The following is a description of a gene set: The aim of this study is to survey global gene expression of total thymocytes from wild-type mice and Atg16l1 mutant (hypomorph) mice. from publication Cadwell K, Liu JY, Brown SL, Miyoshi H, Loh J, Lennerz JK, Kishi C, Kc W, Carrero JA, Hunt S, Stone CD, Brunt EM, Xavier RJ, Sleckman BP, Li E, Mizushima N, Stappenbeck TS, Virgin HW 4th (PMID 18849966) Genes up-regulated in tymocytes: mutant (hypomorph) ATG16L1 versus wildtype. Human Gene Set: GSE12707_AT16L1_HYPOMORPH_VS_WT_THYMUS_UP species: Homo sapiens, and this is the list of marker genes: PES1 (NCBI Gene Id 23481), BCCIP, ASB2, NASP, CFI, NT5C1B, ANK2 (ankyrin 2), TMPRSS11D, LELP1, GUCY1B2, COPS3 (COP9 signalosome subunit 3), GJA4, MRPL16, RNASEH2B, PEX11A, LIAS, CD177 (NCBI Gene Id 57126), CFAP144P1, HELLS, SLC16A11, NGRN (NCBI Gene Id 51335), BTBD10, MRTO4, NUP155, LY6S, CTH, ACSF3, NKG7, TMEM30CP, ACP1, THNSL2, TMEM198, TXNL4B, AMPH, DEPDC1, EZH2, BRD8 (bromodomain containing 8), PRL, RAB27B, PLPP3, KIF14, PMAIP1, RAD1, RCL1, DCLRE1A, CSE1L, BRIX1, SEPTIN2, RAF1, CD14, CYP8B1, GAP43, TMX1, RPL17, MARVELD3, SERPINB12, UCHL5, ARHGAP36, DENND6B, GYS2, GRIA3, GALNT6, MIR20A, NF2, LCLAT1, TPK1, CPQ, DNAJB11, IFNG, SPAG1, TSPAN15, NR1H5P, ASAH2, HMGN3, PEX2, JAG1, NCF1 (NCBI Gene Id 653844), SCARNA13, RTN4IP1, BMPR1B, MIR466 (NCBI Gene Id 100423038), PGD, ALG12, BRCA2, PTPN3, RAP2A, TCEAL8, HOXC6, NUDT21 (NCBI Gene Id 11051), PLSCR2, DNAJC25, ATP6V1A, SNX1, PDK3, LILRB4, MECR, POLA1, OXSM, INTS4, STOM, HMGB1, CNTNAP4, PNO1, GJA1, KCNQ5, FTO, CEACAM5, ZMPSTE24, CEP57, GRK1, PROCA1, CLDN1, CPNE6, SAA4, ADCY8, FAM124B, PLP1, TMEM69, CSF2, EDA, USP6NL, CHORDC1, CRHR1, TMEM165, GEM, RGS9, SARNP, ACTN2, TMPRSS13, SEC14L3